Given this list of marker genes DCP2, EXOSC2, EXOSC5, NFYC, DDIT3 (NCBI Gene Id 92982), CEBPG, EXOSC6, CEBPB, EXOSC4, CCL2, HERPUD1, ATF4, IGFBP1, EXOSC7, NFYB, EXOSC9, ASNS, EXOSC1, PARN, ATF3, KHSRP, ATF6, NFYA, EXOSC8 (exosome component 8), DIS3, CXCL8, EXOSC3, here is a description of the gene set: Reactome Pathway: ATF4 activates genes in response to endoplasmic reticulum  stress studied in species Homo sapiens ATF4 is a transcription factor and activates expression of IL-8, MCP1, IGFBP-1, CHOP, HERP1 and ATF3. part of: PERK regulates gene expression